The following is a description of a gene set: Human Gene Set: GOBP_POSITIVE_REGULATION_OF_CELL_MATURATION species: Homo sapiens Any process that activates or increases the frequency, rate or extent of cell maturation., and this is the list of marker genes: AURKA, TMPRSS12, CLEC7A, BNC1, ADAM7, MAP3K13, BCL2, SIRT2, NGF